Given this list of marker genes PPP1R3B, FASN, PPP1R3E, PCYT1A, PPP1CA, PPP1R3D, here is a description of the gene set: Cytoplasmic bead-like structures of animal cells, visible by electron microscope. Each granule is a functional unit with the biosynthesis and catabolism of glycogen being catalyzed by enzymes bound to the granule surface. Human Gene Set: GOCC_GLYCOGEN_GRANULE studied in species Homo sapiens